The following is a description of a gene set: Human Gene Set: FOXG1_TARGET_GENES Genes containing one or more binding sites for (FOXG1) in their promoter regions (TSS -1000,+100 bp) as identified by GTRD version 20.06 ChIP-seq harmonization. studied in species Homo sapiens from publication Yevshin I, Sharipov R, Kolmykov S, Kondrakhin Y, Kolpakov F (PMID 30445619), and this is the list of marker genes: TEDC1, ZC3H10, VILL, CHORDC1, GANC, SPATS2L, GTF2H4, RILPL2, LPCAT3 (lysophosphatidylcholine acyltransferase 3), USP35, GPALPP1, TULP3, ECSIT, UQCRH, DAXX, YY1AP1, ZFC3H1, SNORA16A, NADK2, CAMSAP2, ZNHIT1, SNX17, SLC41A2, CCT8, PISD, NUB1, SCARNA16, UTP25, CCNT2-AS1, OAZ2, FBXO33, MIR3677HG, SNORD15A, DET1, ABCF2 (NCBI Gene Id 11195), TMED2, RIMOC1, RPL7L1P8, NUFIP1, IFRD1, WDR83, DHRS1, DUSP6 (NCBI Gene Id 1848), AHI1-DT, CEP120, MVK, SLC50A1, ENSG00000266401, TOB1, ZMYM4, PRCP, HECW2-AS1, TBC1D30, SLC39A10, ARPC4-TTLL3, COPS4, HAGH, RNF10, MRPL13, POC1B, UBP1, KRI1, NAA15, GABPB1, ENPP3, ITPRIP, RALY, RNVU1-22 (NCBI Gene Id 106481627), PSMG4, DCAF7, MIR4521, C14orf119, CEP350 (centrosomal protein 350), INO80E, SMPDL3B, ZNF207, COQ10B, MAN2C1, ATF2, MICOS13, BYSL, PPP6R2, GRHL3, CAPRIN2, MIR3141, FAM200C, RNASEH2C, AP5Z1, PCDH1, CCDC6, NDUFC1 (NADH:ubiquinone oxidoreductase subunit C1), DDX21, MFAP3, NDUFB1, RBM26, TDRKH, DPP9, MIR4512 (microRNA 4512), ILF2, TIGD2, ECE2, NDUFB2-AS1, TADA3, SERPINI1, MBP, ZER1, DMXL1, TBC1D17, CPSF3 (NCBI Gene Id 51692), H4C1, HOMER1 (homer scaffold protein 1), CDC73, SQSTM1, C1orf159, RABGEF1, MRFAP1, ITGB1BP1, MAZ, SOS1, MPHOSPH9, SEPTIN7, MRPS31, DISP2, FENDRR, COPA, REV3L, KPNB1, POLK, CNPY2-AS1, GGA1, TMEM217, INPP1, LSR, SPRED2, POGLUT1, TNPO3, NFX1, C2CD5, MDH2, LIN37, CCNT2, TSPAN31, SLC16A13, ARID2, ELMOD3 (ELMO domain containing 3), NCLN, RAB14, WDR36, NASP, PCBP2, C19orf48P, TMED10, OTUD7B, MRFAP1L2, EARS2, RAB11A, LINC00938, TLCD1, ZNF12, UBE2I, LMAN2, PSMA5, NEK8, PRPF4, ALS2, TPR, PRMT9, ARID4B, TXNDC12, RPL7P30, PRKCI, EHF, SPRY4, RAB4B-EGLN2, TMEM144, EXO1, SNHG20, DNAJB12, PPRC1, TMEM170A, HSD11B1L, VTRNA1-2, UQCC6, TEX2, AHI1, PPIL3, TBC1D22B, MAPK6, LRRC41, CDC26, MIR5091, SLC30A10, DDX41, ERCC5, FCHO2, CNIH1, PCBP1-AS1, TDRKH-AS1, TM9SF4, MDM2, NBPF25P, PHF14, COG6, NSA2 (NCBI Gene Id 10412), TPI1P2, CA11, DEPDC4, GFM2, SERPINB1, AHNAK, C1orf226, SPRYD4, CEP63, LIN7C, CBX8, HNRNPM, MLST8, PCBP1, LZTR1, GIT2, IL6ST, DEPDC1B, TXN2, GTF2IRD1P1, TYW5 (tRNA-yW synthesizing protein 5), TLN1, ABCC5, TRAF3IP2-AS1, CENPM, COASY, H1-4, FAF2, MGRN1, CCDC87, CLIP1, RAP1GDS1, ABCA7, POLG2, ENO1, TMEM259, TRIM32 (NCBI Gene Id 3971), RTF1, SEPTIN7-DT, ESYT1, UROD, TSPAN1, ZBED5-AS1, FAU, MAIP1, GRHL3-AS1, TM2D1, STYXL1, ENC1, BSDC1, TBL1XR1, PARP6, MDH1 (NCBI Gene Id 4190), IPO11 (NCBI Gene Id 51194), BLTP1, PSPC1, LARS2, CCT3, SRSF4, TMEM223, TOMM22, ZNF687, CELSR3, ITGB1, EYA3, RAPGEFL1, CCT2, LINC02482, SLC4A1AP, SNX30, MATR3, ZNF786, TRAJ7, MAML1, ODR4, NIF3L1, MAPKBP1, PPOX, BCL11A, GPNMB, UTP18, CBX5, MAPK6-DT, AOPEP, NCSTN, OGA, SNORD43, TMED7, EHBP1, SCYL2, CBX3, DIMT1, TRMT10C, WDR55, NDUFB2, BDNF-AS, TCEA1, ENO1-AS1, BRCA2, TANK, RALBP1, OASL, PDP2, HIKESHI, RNPS1, MARF1, DDIAS, MBTD1, GID8, TBX3, RIMKLB, FUT11, MTHFS, ZYX, SNAPC5, LINC02739, ARMC6, RNVU1-4, SMARCAL1, TMED7-TICAM2, ZFYVE19, USE1, MINDY2-DT, COPZ1, IP6K2, SLC16A1-AS1, SEC14L1, POLR2M, ZNF280D, TCF12, LSM11, B3GALNT2, WDPCP, RTN4, RBM3, CYB5D1, CCNL1, SH3RF2, BOD1L1, SELENOW, BICD1 (NCBI Gene Id 636), GLYCTK, SNUPN, LINC02585, LINC02454, SSBP2, TXNDC15 (thioredoxin domain containing 15), EFCAB6, KNL1, DMXL1-DT, HECTD3, RNF216, NARS2, YARS2, EIF2D, BBC3, VAMP1, RPL24, FMNL2, RIC8B, SNHG12, HIBADH, CRY1, EIF2B4, DENND4A, RANBP2, STK11IP, DENR, VARS2, RBM47, MMAB, FASTK, MRPS16, CHCT1, SECISBP2L (NCBI Gene Id 9728), NAPA-AS1, KCTD21, ENTPD4, LINC01623, FBRS, LIMA1, TRMO, TSACC, ZNF770, RNF145, EPCAM, ITFG2, SLC35F2, DDIT4 (DNA damage inducible transcript 4), PDF, LRRC1, MIR4734, PCNX3, PIGO-AS1, ACP3, NUDT3, DIAPH1, ALDOA, TMEM106B, VPS4B, CDKL3, SNX30-DT, USP32, RETSAT, GHDC, PSMC2, MIR22HG, DENND5B-AS1, DUS4L, FAM131B-AS2, MTBP, ARID1A, KPNB1-DT, POLR2H, FKBP14, CSRNP2, CCS, C17orf75, DNAAF3, RPS29P16, NDUFAF1, CDC42EP4, LGR6, ATG101, TOMM22-DT, ZNF446, AMACR, ZAR1L (NCBI Gene Id 651802), SRI, FCHO2-DT, ITGB1-DT, DHX16 (DEAH-box helicase 16), AKT1S1, GAPDH, DVL2, MRPL47, RAB28, BNIP1, MITD1, SETD1A, SERINC4, PDCD10 (programmed cell death 10), PLEKHA8, PDE12, RAB4B, OTUB2, ATP6V1B1-AS1, SUGP2, WWP2, CHAC1 (NCBI Gene Id 79094), RSL24D1, SUGCT, HNRNPA1, RN7SL181P, SFSWAP, MARCHF3, FOXN2, BTF3L4, ENTPD4-DT, KIFBP, GPR89A, UBXN2A, UBE2B, SREBF2, MTRFR, SMAD6, GARIN5A, CSE1L-DT, WDR83OS, PRR13P5 (proline rich 13 pseudogene 5), NOP9, ASTN2, ACAT2, GABPB1-AS1, AFTPH-DT, AMN1, TMEM39A, MPLKIP, CLTC, CCZ1P1, CFAP43, RPL36, AVPI1 (arginine vasopressin induced 1), REXO4, ASH1L, PDE4D (phosphodiesterase 4D), CERT1, PIGO, ZNF490, INKA1, SIL1, DDX17 (NCBI Gene Id 10521), SLC25A51, FIBP, SIDT1 (SID1 transmembrane family member 1), TMEM14A, GCN1, RSPH3, MACROD1, COL17A1, EMC10, GCHFR, MRPL36, MIR933, RPS3, HYAL2, EHD4, TARS2, KCNIP2-AS1, SUPT7L, TRAP1, MLKL, FAM114A2, FUZ, RPL3, WDSUB1, PIWIL2, AP5S1, SYPL1, SEMA4B, GTF2A1, MED20, ARMC2, CALM2, ZNF747, PAFAH2, BCL2L11, INTS2, ENSG00000239137, FDFT1, FAM76A, CS, THAP2, MRPL49, WDR82, SLC28A2-AS1, XRCC2, FAHD1, SRA1, DNMBP, NAA38 (N-alpha-acetyltransferase 38, NatC auxiliary subunit), MINDY2, UBFD1, DNAJC2, PLAC8, ADGRE2, GTF2A1-AS1 (NCBI Gene Id 101928504), PLOD3, DAP3 (death associated protein 3), HNRNPA2B1, CPSF2, SLC9A1, DIAPH1-AS1, GRK6, CHMP7, HIRIP3, BZW1, ANKMY2, ZBED5, FDPS, KANSL1, SDR39U1, MAP3K11, SINHCAF, EXOSC9, MIR3913-1, RNU5A-1, ITFG2-AS1, SAMD4B, DYNC2I1, ACTB, KPTN, SPNS1, PRR13, RNU6-2, TMEM87A, RIOX1, HELLS, ARPC4, SEC31A, ATP1A1-AS1, NDUFB5, MRPL30, BZW2, TUBA1B-AS1, AFTPH, GGPS1, GOLGA5, SEH1L, ZNF747-DT, BRPF3, SMIM2-AS1, TUBA1B, MED23